The following is a description of a gene set: species: Homo sapiens Proliferation of astrocytes in the area of a lesion of the central nervous system. Astrocytosis Human Gene Set: HP_ASTROCYTOSIS, and this is the list of marker genes: MT-ATP6, GRN, STRADA, CHMP2B, SQSTM1, ERCC6, TREM2, TSC1, MTOR, SLC30A10, ERCC8, LAMA2, NUP54 (nucleoporin 54), PRNP, TSC2, VCP, POLG, TMEM106B, ADAR, NUP62, PSEN1, MAPT